Given this list of marker genes PELI1, UBXN1, UBE2V1, UBE2C, PER2 (NCBI Gene Id 8864), RPL23, CHFR, RPL11, PLAA, DTX3L, BAG5, SVBP, MAGEC2, PRKCG, MYCBP2, VPS28, GPS2, RIPK2, CTNNB1, SIRT7, U2AF2, FBXW7, BCL10, HDAC8 (NCBI Gene Id 7492), CBLB, MAGEA2, FBXO4, BEX3, N4BP1, CDK5, STUB1, MAPK9, CHP1 (calcineurin like EF-hand protein 1), HSP90AA1, CRY1, KDM1A, RPS2, PARP10, TRAF6 (NCBI Gene Id 7189), UBE2N, TICAM1, BMI1, DNAJA1, UBE2V2 (ubiquitin conjugating enzyme E2 V2), BIRC7, RASSF1, BEX1, BTRC, GNL3L, NGF, NSMCE3, NPM1, DNAJB2, SKP1, PINX1, TRIM44, FZR1, TSPO, NMI, BEX4, BIRC2, HSPA1B, KLHL40, SPHK1, AKT1, CDK5RAP3, MALT1, PSMD10, ABL1, TBC1D7, BIRC3, CDKN2A (cyclin dependent kinase inhibitor 2A), ISG15, FAM107A, NDFIP2, INAVA, BEX2, PARK7, PABPN1L, CDC14B, HDAC3, CAV1, ARRDC3, ANGPT1, MARCHF6-DT, LRRK2, DAXX, CDC20, TRIB3, SPSB4, NHLRC1, UBQLN1, PINK1, UBXN2A, PRICKLE1, IVNS1ABP, UFL1, SPRTN, LAPTM5, HSPA1A, AIMP2, MARCHF7, RNF180, PRKN, TAF1, FBXO5, ARRB1, PPIA, AXIN1, PAXIP1 (PAX interacting protein 1), GSK3A, GCLC, BIRC8, EPM2A, SQSTM1, HERPUD1, PTTG1IP, MTBP (MDM2 binding protein), TNFAIP3, WASHC1, PHF23, OGT, WDR48, UBE3A, AMER1, SASH1, HAMP, PDCD6, RPS7 (ribosomal protein S7), UBE2L3, NOD2, SH3RF2, NDFIP1, MAGEA2B, FANCM, RBX1, HSP90AB1, SPRY2, MAD2L2 (mitotic arrest deficient 2 like 2), SIAH2, DNAJA3, RCHY1, HUWE1, DDX3X, TTC36, HSPA5, CUL3, WFS1, DERL1, HSPBP1, GSK3B, CENPX, PLK1, TCF25, SEPTIN4, FOXF2, MINAR1, SENP2, FYN, ATG5, SPOPL, MIR101-1, FBXO33, PEF1, MIR138-1, NXN, XIAP, GTPBP4, PTPN22, PRKCE (NCBI Gene Id 5581), MAD2L1, COMMD1, UBE2D1, CEP78, ARRB2, RPL5, SKP2, WNK1, UBE2S, FBXO2, ARRDC4, FANCI (FA complementation group I), PRMT3, USP44, ADGRB1, MTA1, CENPS, RPS3, BAG2, TSPYL5, WBP1L, RASSF5, DCUN1D1, UBB, CAMLG, CEP63, USP4, RNF111, TGFBR1, GABARAP (NCBI Gene Id 201246), here is a description of the gene set: Human Gene Set: GOBP_REGULATION_OF_PROTEIN_UBIQUITINATION studied in species Homo sapiens Any process that modulates the frequency, rate or extent of the addition of ubiquitin groups to a protein.